Given this list of marker genes Cdk11b, Bub1, Naa10, Sgo1, Naa50, here is a description of the gene set: The cell cycle process in which centromeres of sister chromatids are joined during mitosis. species: Mus musculus Mouse Gene Set: GOBP_MITOTIC_SISTER_CHROMATID_COHESION_CENTROMERIC